The following is a description of a gene set: studied in species Homo sapiens Human Gene Set: GOMF_MICROTUBULE_SEVERING_ATPASE_ACTIVITY Catalysis of the reaction: ATP + H2O = ADP + phosphate. Catalysis of the severing of a microtubule at a specific spot along its length, coupled to the hydrolysis of ATP., and this is the list of marker genes: KATNAL2 (katanin catalytic subunit A1 like 2), FIGNL1, FIGN, FIGNL2, IQCA1, KATNA1, SPAST, IQCA1L, KATNAL1